Given this list of marker genes XPA, TONSL, CDC5L, RPA4, RPA2, PRPF19, PLRG1 (pleiotropic regulator 1), RPA1, BCAS2, ERCC5, SMARCAL1, RPA3, HELB, here is a description of the gene set: studied in species Homo sapiens Human Gene Set: GOCC_DNA_REPLICATION_FACTOR_A_COMPLEX A conserved heterotrimeric complex that binds nonspecifically to single-stranded DNA and is required for multiple processes in eukaryotic DNA metabolism, including DNA replication, DNA repair, and recombination. In all eukaryotic organisms examined the complex is composed of subunits of approximately 70, 30, and 14 kDa.